The following is a description of a gene set: A protein complex that acts as an activin receptor. Heterodimeric activin receptors, comprising one Type I activin receptor and one Type II receptor polypeptide, and heterotrimeric receptors have been observed. species: Mus musculus Mouse Gene Set: GOCC_ACTIVIN_RECEPTOR_COMPLEX, and this is the list of marker genes: Acvr1, Acvr1b, Acvr2b, Tgfbr2, Acvr2a, Acvr1c, Tgfbr1